The following is a description of a gene set: Increased height of the central portion of the eyebrow, forming a crescent, semicircular, or inverted U shape. species: Homo sapiens Human Gene Set: HP_HIGHLY_ARCHED_EYEBROW Highly arched eyebrow, and this is the list of marker genes: TBX4 (NCBI Gene Id 9496, T-box transcription factor 4), ZSWIM6, CHD8, NAA80, TGDS, SPECC1L, GJA8, CSNK2A1, CBL, RAD21, ARL3, EP300, GJA5, TAF4, PTPRF, COLEC11, PDE6D, AFF4, NEUROG1 (neurogenin 1, NCBI Gene Id 4762), FAR1, ACBD6, ESCO2, SPOP, KIFBP, SUPT16H, C12orf57, KCNH1, TFAP2B (transcription factor AP-2 beta), SETD2, SMARCA2, FBXO11, MESD, NFIX, FOXL2 (NCBI Gene Id 668), NSD2, SOX11, IFT74, CRKL, TOGARAM1, KDM1A, TAF6, TWIST2 (twist family bHLH transcription factor 2), BRD4, MEGF8, LTBP1, ACTG1, MASP1, FRMD4A, ECEL1, NPHP1, CEP104, ERI1, BCOR, MED27 (mediator complex subunit 27), MAPK1, LRPPRC, SPEN, PIGG, ZNF423, SZT2, FREM1 (NCBI Gene Id 158326), CDC42BPB, SMAD4 (NCBI Gene Id 4089), BICRA, NUP188, ANKRD11, PIGW, OFD1, MAN2C1, SETD5, NELFA, AHI1, EHMT1, AUTS2, CREBBP, CYFIP2, CHD7, COLEC10, MKS1 (MKS transition zone complex subunit 1), KMT2A, SMPD4, TASP1, MN1, BCR, ESAM (endothelial cell adhesion molecule, NCBI Gene Id 90952), SHMT2, SMC3, KIF7, RAC1, ZEB2, TMEM237, KMT2D (NCBI Gene Id 8085), IGF1R (NCBI Gene Id 51049), TRIO, FAM20C, CTU2, MEIS2, MAN1B1, RAP1GDS1, ZFX, HDAC8, FGFRL1, PGAP1, TMEM218, PGAP2, STRADA, SV2A, PUF60, TMEM216, CPLX1, PACS1, CHSY1, KCNK9, PPP1CB, CTBP1, KIAA0586, CDK13, CEP41, RPS6KA3, CASK, CPLANE1, PGAP3, TMEM231, ZNF462, TMEM67 (transmembrane protein 67), HDAC4, TMEM138, PLAA, CHST3, GAD1, RHOBTB2, STAG2, VPS35L (VPS35 endosomal protein sorting factor like), AFG2A, MADD, STXBP1, TBCK, MAN2B1, MBD5, NECTIN1 (NCBI Gene Id 84853), TMCO1, TCTN1, ARMC9, RUSC2, CEP120, RPS23, CAMK2G, SEMA3E, HSPA9, PIGY, CSPP1, B9D1, FAM149B1, LETM1, ERMARD, NIPBL, TMEM94, PPP2R3C, NCAPG2, H4C9, ROBO1, KAT6A, PIGS, CEP295, ADAT3, KDM6A, FGFR1, CTCF, POGZ, DDX6, CDC42, COX7B, TOPORS, KIAA0753, PIGL, PUS7, ACTB, PIGO, CDH11, OTUD6B, RNF2, PIGV, WASHC4 (WASH complex subunit 4), UGP2, ASPM, TCTN3, SLC45A1, TRRAP, H4C11, SUFU, PRR12, PIBF1, INPP5E, CBY1, HYLS1, CC2D2A, CEP290 (NCBI Gene Id 9707), ZBTB18, B9D2, TCTN2, FBXO31, SMC1A, ASXL2, KATNIP, CLP1, TTC5, CLCN6, LMX1B (NCBI Gene Id 4010), RPGRIP1L, ASXL3, HNRNPH1, ARL13B